Given this list of marker genes Atp8a2, Tnnc1, Gaa, Selenon, Ddit3, Adrb2, here is a description of the gene set: species: Mus musculus A process in which force is generated within involuntary skeletal muscle tissue, resulting in a change in muscle geometry. Force generation involves a chemo-mechanical energy conversion step that is carried out by the actin/myosin complex activity, which generates force through ATP hydrolysis. Involuntary skeletal muscle is skeletal muscle that is not under conscious control. Mouse Gene Set: GOBP_INVOLUNTARY_SKELETAL_MUSCLE_CONTRACTION